The following is a description of a gene set: part of: Downstream signaling of activated FGFR2 electronically inferred by orthology from the curated human pathway species: Mus musculus This event has been computationally inferred from an event that has been demonstrated in another species.<p>The inference is based on the homology mapping from PANTHER. Briefly, reactions for which all involved PhysicalEntities (in input, output and catalyst) have a mapped orthologue/paralogue (for complexes at least 75% of components must have a mapping) are inferred to the other species. Reactome Pathway: PI-3K cascade:FGFR2, and this is the list of marker genes: Frs2, Fgf6, Fgf16, Fgf5, Fgf4, Fgf2, Gab1, Fgf23, Fgf17, Fgf8, Grb2, Fgf22, Fgf1, Fgf20, Fgf10, Fgf7